The following is a description of a gene set: Any process that modulates the rate, frequency or extent of the formation of a lamellipodium, a thin sheetlike extension of the surface of a migrating cell. Mouse Gene Set: GOBP_REGULATION_OF_LAMELLIPODIUM_ASSEMBLY species: Mus musculus, and this is the list of marker genes: Hdac4, Twf2, Mtor, Akirin1, Aqp1, Cfl1, Wasf2, Hrg (NCBI Gene Id 94175), Carmil2, Plxnb3, Epha2, Twf1, Abi3 (ABI family member 3), Arpc2, Nckap1, Bin3, Was, Dnm2, Fer, Cdc42, Dmtn, Pik3r1, Rac1, Mstn, Wnt1, Hsp90aa1, Cyfip1, Clrn1, Abi2, Rac2, Atp7a, Plce1, Capzb, Brk1, Frmd7, Fscn1, Avil, Auts2, Actr3, Slit2, Actr2